Given this list of marker genes TM4SF4, EXOSC2, MAP3K10, TXNL1, TIMM8A, NBL1, MAP2K3, TCP11, RAN, RCN1, CRYM, VGLL3, PHB1, KL, CCL4 (NCBI Gene Id 6351), SETD6, DDX21, ATP2B1, ING1, ITGB1BP2, SNAPC1, ZNF778, AUTS2, TOMM40, SGTA, ARHGEF2, ESR2, KPNA1, GABPB1-IT1, PTK2, PKNOX2, ATG101, CRY1, PSMD12, PIGL, IRF4, SERINC5, KRT84, AK2, EIF3J, NETO2, GNAS, GPX3, SCGN, RRAD, GRM1, EIF3D, METTL13, GPR35, NEU3, TAL1, ULK4, COPS2, IL11, WDR4, OTUD7B, EIF2B2, VEGFA, NELFE, U2AF1, KRR1, ABCE1, SLC25A44, EXOSC4, CHUK, KLK2, RAB22A, PSME3, ZNF280A, CHD4, NUP88, UXS1, VCL, TGS1, ALG3, GSE1 (NCBI Gene Id 23199), ZNF551, POLR1B, TLE3, PSMD1, TENT4A, TGFBR2, EIF5B, LRRFIP1, PMPCA, AIMP2, H3C12, RPL8, EIF3G, MAGEL2, TIMM17A, OLFM1, HNRNPC, CEP170B, SNHG3, PDCD11, CD83, PRR36, GLUD2, OVOL2, RIN3, KCNK10, PRNP, PHB2, TAF9, ARF4, TREX2, ADGRE5, ZNF614, GOLIM4, NFIL3, TNFRSF10D, TTF2, ESF1, IFNG, CTAG2, UMPS, LAMA2, ENC1, TRAV12-2, IL17RC, PLAAT1, NUP98, EMC8, IL5, GABRG3, TTC33, SLA, MRPL17, KRTAP5-8, DESI1, BLTP3B, GNL2, TNIP3, KIAA0513, TEX41, DNAJB9, TBL1X, TICAM1, NIP7, PNO1, RAB3GAP1, SLC25A32, MKLN1, CSF1, UCHL3, EMC1, TNFSF9, SFXN1, ZFP36L1, RBM8A, MYLIP, MAPRE2 (microtubule associated protein RP/EB family member 2), CD82, GJC1, EBI3, SLC12A3, OGFOD1, RPL35A, OTUD4, LCE2B, STX1A, TNFSF14, METTL22, IL2RA, RGS1, EZR, HEATR1, DDX49, SDCBP, HOMER1, PHF1, CMAHP, FNBP1, SEC14L2, NFAT5, KYNU, NDEL1, DPH2, GPR183, SEMG1, PHLDB1, KIF1B, ABCF3, MAGEA10, PPA1, KLHL18, AARSD1, CCR4, YARS2, POLR3E, DDX10, CEACAM8, YIPF6, NAP1L1, CEBPG, PPFIA1, MIF (NCBI Gene Id 4282), GLRX5, TNP2, here is a description of the gene set: Human Gene Set: GSE37301_COMMON_LYMPHOID_PROGENITOR_VS_GRAN_MONO_PROGENITOR_UP Expression profiling of Rag2-deficient Ets1++ and Rag2-deficient Ets1-- mature NK cells and WT bone marrow progenitors, WT T cells, and WT Pro B cells Genes up-regulated in common lymphoid progenitors versus granulocyte-monocyte progenitors. studied in species Homo sapiens from publication Ramirez K, Chandler KJ, Spaulding C, Zandi S, Sigvardsson M, Graves BJ, Kee BL (PMID 22608498)